Given this list of marker genes Dna2, Kif6, Dhx32, Ddx19a, Kif21a, Ercc3, Dnah14, Dnah11, Trp53, Top3a, Recql, Dhx8, Myo1g, Dhx37, Fign, Mcm3, Myh4, Myh7b, Dnah1, Cenpe, Kifc1, Myh1 (myosin, heavy polypeptide 1, skeletal muscle, adult), Dync1h1, Dnah12, Ddx59, Pif1, Ruvbl1, Kif2c, Dnai2 (dynein axonemal intermediate chain 2), Kif27, Katnal1, Myo3b, Recql4, Chd5, Aqr, Dhx30, Kif19b, Dhx9, Myo1b, Myo9b, Twnk, Top2a, Mov10l1, Chd9, Kif2b, Eif4a1, Dnah7c, Ddx20, Rad50, Top3b, Kif5c, Kif19a, Supv3l1, Dnah8, Smarcad1, Ep400, Wrn, Mre11a, Eif4a3l2, Rfc5, Top1mt, Blm, Fignl1, Mcm2, Myh3, Spast, Kif16b, Mcm4, G3bp1, Chd8, Psmc1, Smarcal1, Dnah3 (dynein, axonemal, heavy chain 3), Rad54b, Dhx36, Dnhd1, Myo7a, Xrcc5, Dhx38, Tnnt2, Chd7, Myo5a, Rigi, Dhx15, Tdrd12, Dhx16, Kif20a, Kif24, Myh8, Ddx28, Kif22, Anxa1, Ddx46, Psmc6, Kif21b, Myo1e, Spo11, Psmc5 (protease (prosome, macropain) 26S subunit, ATPase 5), Nav2, Myo5c, Mcm7, Ythdc2, Chd1, Mtrex, Ddx1, Dync2h1, Myo19, Chtf8, Katnal2, Rfc4, Rad54l, Skic2, Zgrf1, Myh14, Dnah17, Myo1d, Ddx50, Kif28, Ddx3y, Ddx10, Smarca5 (NCBI Gene Id 93762), Ddx17, Ddx39a, Fancm, Dnah2, Kif26b, Polq, Kif13a, Myo7b, Ddx24, Ddx11, Myo1f, Kif7, Actc1, Dync1li1, Dync1i1, Ddx4, Ddx55, Dhx29, Kif12, Psmc3, Kif3b, Mcm8, Myo10, Mcm6, Ddx56, Setx, Dqx1, Myo1a, Ddx51, D1Pas1, Sub1, Dhx35, Mov10, Kif26a, Helq, Myh10, Smarca2, Myl6, Ddx6, Top6bl, Psmc4, Myh13, Kif20b, Eif4a3, Dnah9, Kif1a, Katna1, Kif4, Kif3a, Psmc2, Eif4b, Kif5a, Chd1l, Myo3a, Ruvbl2, Chd2, Dhx34, Fmr1 (NCBI Gene Id 207836), Myo9a, Hells, Myo5b, Ddx3x, Stard9, Gtf2f2, Rad51, Myh6, Fbh1, Kif2a (kinesin family member 2A), Hnrnpa1, Fxr1, Dhx58 (NCBI Gene Id 93832), Ercc6l, Xrcc6, Rfc2, Ddx54, Chd6, Ddx19b, Tdrd9, Dnah7b, Ddx52, Ddx5, Eif4a3l1, Rtel1, Kif13b, Myo1c, Smarca1, Ifih1 (interferon induced with helicase C domain 1), Ddx25, Ddx42, Dicer1, Ddx18, Ddx49, Rfc3, Myo15a, Eif4h, Kif18a, Myh15, Kif18b, Dhx40, Dnah5, Kif1b, Myo6, Brip1, Ddx31, Mcm9, Myo1h, Ighmbp2, Myh11, Chd4, Kif23, Ddx47, Kif9, Myh7, Znfx1, Ddx43, Kif1c, Ddx21, Kif5b, Helz2, Dhx57, Top1, Kifc5b, Fignl2 (NCBI Gene Id 668225), Ercc2, Kif11 (kinesin family member 11), Dscc1, Hltf (helicase-like transcription factor), Myh2, Helz, Ddx39b, Kif14, Rad54l2, Mcm5, Kifc3, Recql5 (NCBI Gene Id 170472), Kif15, Zranb3, Atrx, Myh9, Ddx27, Snrnp200, Hfm1, Smarca4, Chtf18, Ercc6, Cftr, Upf1, Ascc3, Kifc2, Ercc6l2, Wrnip1, Dnah7a, Top2b, Eif4a2, Ttf2, Shprh, Helb, Kif17 (kinesin family member 17), Ddx41, Dhx33, Dnah10, Dnah6, Kif3c, here is a description of the gene set: Mouse Gene Set: GOMF_MACROMOLECULAR_CONFORMATION_ISOMERASE_ACTIVITY Catalysis of a reaction that alters the macromolecular conformation of a molecule. species: Mus musculus